Given this list of marker genes FAS, TGFB1, STK11, PUS1, KCNE1, GATA1, IRX5, HLA-DQA1, HBG1, GALNT2, C2orf69, TRNT1, CLPX, KLF1, OSTM1, ALG2, HBB, FN1, EIF2AK3, PLA2G4A, ALAS2, ABCD3, HLA-DQB1, HBG2, MMP1, FOXP3, IREB2, COL2A1, KARS1, FASLG, HSCB, DNAJC19, CASP10, HBA1, BCL11A, LPIN2, TF, NAA10, WAS, TMPRSS6, CP, ATRX, TET2, ELMO2, CARD10, CYP2R1, FGF23 (fibroblast growth factor 23), TAFAZZIN, APC, DIAPH1, KCNQ1, ZNF699, SLC12A3, CD55, ABCB7, SHPK, CLCNKB, CYP27B1, SF3B1, COL7A1, HBA2, ELF4, here is a description of the gene set: Human Gene Set: HP_HYPOCHROMIC_ANEMIA Hypochromic anemia species: Homo sapiens A type of anemia characterized by an abnormally low concentration of hemoglobin in the erythrocytes.